Given this list of marker genes Nr2f1, Tgfbr1, Ets1, Srf, Gata3, Foxo3, Nfkb1, Pnpt1, Bmpr1a, Agt, Hif1a, Il10, Apln, Pparg, Spi1, Gata2 (GATA binding protein 2), Zc3h12a, Jun, Stat3, Zswim8, Smad6, Gnl3, Atoh8, Myc, Bmyc, Notch3, Fos, Notch2, Lin28b, Pdgfb, Smad3, Gata4, Srebf1, Myocd, Rela, Klf5, Tead1, Trp53, Tnf, Myb, Ar, Mrtfa, Mrtfb, Prl, Wt1, Nr1h2, Egr1, Fosl1, Tert, Dicer1, Tgfb1, Ngfr, Klf4, Pax6, Smad4, Smarca4, Bmp2, Smad1, Bmp4, Ctcf, Tgfb2, Nr3c1, Egfr, Srebf2, Hras, here is a description of the gene set: Any process that activates or increases the frequency, rate or extent of miRNA metabolic process. species: Mus musculus Mouse Gene Set: GOBP_POSITIVE_REGULATION_OF_MIRNA_METABOLIC_PROCESS